Given this list of marker genes FGF1, ITGAX, ADAMTS12, LCN2, MIR21, CXCL10, FOXP1, here is a description of the gene set: Human Gene Set: GOBP_REGULATION_OF_ENDOTHELIAL_TUBE_MORPHOGENESIS species: Homo sapiens Any process that modulates the frequency, rate or extent of endothelial tube morphogenesis.